The following is a description of a gene set: The regulated release of a gonadotropin, any hormone that stimulates the gonads, especially follicle-stimulating hormone and luteinizing hormone. studied in species Mus musculus Mouse Gene Set: GOBP_GONADOTROPIN_SECRETION, and this is the list of marker genes: Gja1, Lep (leptin), Oprm1, Inhba, Crhr2, Cga, Tbx3, Tmf1, Acvr2a, Niban2, Npvf, Tacr2, Inha, Foxl2, Inhbb, Foxd1, Crh, Smad4, Oprk1, Ucn2, Kiss1